The following is a description of a gene set: Human Gene Set: GOMF_STEROID_DEHYDROGENASE_ACTIVITY_ACTING_ON_THE_CH_OH_GROUP_OF_DONORS_NAD_OR_NADP_AS_ACCEPTOR Catalysis of an oxidation-reduction (redox) reaction in which a CH-OH group acts as a hydrogen or electron donor and reduces NAD+ or NADP, and in which one substrate is a sterol derivative. studied in species Homo sapiens, and this is the list of marker genes: AKR1C3, HSD17B1 (hydroxysteroid 17-beta dehydrogenase 1, NCBI Gene Id 3292), DHRS1, AKR1C2, RDH16, HSD17B2, RDH5, HSD17B8, HSD17B7, HSD3B7, HSD17B4, AKR1C4, AKR1B15 (aldo-keto reductase family 1 member B15), HSD3B2, HSD17B3, HSD11B1, HSD17B10, CBR3, HSD3B1, HSD17B11, HSD11B2, DHRS9, SRD5A2, AKR1C1, HSD17B12, HSD17B13, DHRS4, NSDHL, HSD17B14, DHRS11, HSD17B6, RDH8